The following is a description of a gene set: Endothelins Human Gene Set: PID_ENDOTHELIN_PATHWAY species: Homo sapiens from publication Schaefer CF, Anthony K, Krupa S, Buchoff J, Day M, Hannay T, Buetow KH (PMID 18832364), and this is the list of marker genes: COL3A1, ADCY5, PRKCE, GNA12, EDN1, GNA11, MAP2K2, CYSLTR1, GNA14, ADCY3, PLA2G4A, CRK, PRKCB, GNAL, SLC9A1, JAK2, GNAQ, GNAO1, RAC1, PLCB3, RAF1, ADCY6, ADCY1, CDC42, MAP2K1, AKT1, GNA15, MAPK14, EDNRA, PLCB1, GNAZ, GNAI1, MAPK8, PRKCA, HRAS, SLC9A3, ADCY4, PRKCH, PRKCG, EDN2, GNAI2, EDN3, MAPK1, EDNRB (endothelin receptor type B), MAPK3, FOS, PLCB2, CYSLTR2, GNAI3, PRKCD, TRPC6, COL1A2, ADCY9, RHOA, MMP1, SRC (SRC proto-oncogene, non-receptor tyrosine kinase), ADCY7, ADCY8, PRKCQ, BCAR1, JUN, ADCY2, PTK2B